Given this list of marker genes PAX8, HNF1B, PAX2, FOXC1, BMP7, FOXC2, here is a description of the gene set: Any process that stops, prevents or reduces the frequency, rate or extent of apoptotic process involved in development. studied in species Homo sapiens Human Gene Set: GOBP_NEGATIVE_REGULATION_OF_APOPTOTIC_PROCESS_INVOLVED_IN_DEVELOPMENT